Given this list of marker genes SYCP2, BLM, RPA1, SYCP2L, BRCA2, REC8, MEI4, RAD51, SYCP3, BRCA1, SMC3, DMC1, SMC1B, INCENP, KASH5, here is a description of the gene set: species: Homo sapiens A proteinaceous core found between sister chromatids during meiotic prophase. Human Gene Set: GOCC_LATERAL_ELEMENT